The following is a description of a gene set: Mouse Gene Set: MIR_5619_3P Genes predicted to be targets of miRBase v22 microRNA mmu_miR_5619_3p in miRDB v6.0 with MirTarget v4 prediction scores > 80 (high confidence targets). species: Mus musculus from publication Chen Y, Wang X (PMID 31504780), and this is the list of marker genes: Rsf1, Hipk3 (NCBI Gene Id 15259), Gpc6, Grsf1, Gabrb2, Sptssa, Cd200, Prdm1, Ccdc93, Lrrfip1, Zmym2, Zbtb34, Ublcp1, Alyreffm13, Ciao2a, Gm6878, Kdm1b, Klhl9, Snap91, Cfap418, Clec2g, Smad2, Ttk, Fzd7, Cyp2j13 (cytochrome P450, family 2, subfamily j, polypeptide 13), Sec61a2, Arhgef7, Dbf4, Tcea1, C4bp, Nav3, Baalc, Picalm, Kpnb1, Ccdc141, Semg1, Zfand6 (NCBI Gene Id 80464), Larp1, Ado, Cnot4, Rfx3, Tle1, Pogk, Kcnd2, Slc9c1, Ski, Nub1, Tmem150c, Hs6st2, Coro2a, Med1, Spag9, Skp1, Alyreffm16, Prdx3, Tsc22d2, Zxdc, Nr6a1, Alyreffm10, Txlng, Resf1, Col12a1, Ldlrad3, Ptprg, Vma21, Fst, Mbd5 (methyl-CpG binding domain protein 5, NCBI Gene Id 98951), Cadps, Alyreffm11, Arid4b, Srgap1, Alyreffm15, Vhl (NCBI Gene Id 22346), Rbm33, Alyreffm14, Rock1, Zbtb33, Rasgrf2, Pdcd6, Sp1, Mpv17l, Dixdc1, Ubr2, Pcdhb13, Cldn11, Ide, Fam131a, Alyreffm17 (Aly/REF export factor family member 17), Mospd2, Asph, Serbp1, Pptc7, Fundc1, Rfx7, Shoc2, Tfap2a, Zfp281, Avl9, Pde5a, Sowahc, Ddhd1, Qser1 (glutamine and serine rich 1), Pld5, Sun1, Krtap24-1, Brwd3, Alox5ap, Rest, Spata3 (spermatogenesis associated 3), Gramd2b, Galnt1, Cbx5, 4931406C07Rik, Sptlc2, Cdkal1, Zhx2, Ephb2, Gad1, Macrod2, Atg16l1 (autophagy related 16 like 1), Dennd5b, Fam117b, Clec2i, Rpl39, Nceh1, Tomm20, Kif5b, Lgr5, Rora, Krtap5-3, Zranb2, Thbs4, Ildr2, Ube2h, Cntn1, Gng4, Cd200r1, Yipf2, Man1a2, Apod, Btn2a2, Maco1, Hsf2, Glce, Pde7a, Dhx32, Fgfbp1, Akt1, Csrp1, Rap1gds1, Mapk1, Suz12, Scai, Acbd5, Arih1, Nkain2, Spock1, Zic4, Zeb1, Pgbd5, Tcerg1, Mbnl3, H2-M10.1, Ube3c, Zcchc3, Cacnb4, Ipcef1, Rbm4b, Cavin1, Set, Dlg2, Srsf1, Senp1, Ces5a (carboxylesterase 5A), Myf5, Slc4a7, Raver2, P4hb, Agpat3, Stox2, Epha7, Lancl1, Pole4, Morc3, Med18, Tcf19, H3f3b, Tmem135, Ppp1r1c, Dcx, Kat2b, Ap3m1, Man1a, Klhl15, Csrnp3, Nufip2, Thsd7a, Serpinb1a, Kdm6a, Diaph1, Trappc8, Fgf16, Plbd2, Zfp706, Cdhr3, Hspa5, Elmod2, Elavl4, Hacd2, Lats2, Iws1